The following is a description of a gene set: from publication Hill JA, Feuerer M, Tash K, Haxhinasto S, Perez J, Melamed R, Mathis D, Benoist C (PMID 18024188) studied in species Homo sapiens The transcription factor Foxp3 is usually considered the master regulator for the CD4+CD25+ Human Gene Set: GSE7460_CTRL_VS_FOXP3_OVEREXPR_TCONV_DN Genes down-regulated in comparison of Ctrlrv versus Foxp3rv (see Fig. 1 in the paper for details)., and this is the list of marker genes: NEPRO, LRP6, NTS, DDX27, MED9, CKAP4, SLC22A15, THAP1, MYBPH (NCBI Gene Id 4608), MPI (NCBI Gene Id 4351), WT1, PYROXD2, METTL26, SECTM1, DTD1, CYTH4, RABGGTB, TMEM273, MMP19, ZNF8 (zinc finger protein 8), RAB27A, BPNT2 (3'(2'), 5'-bisphosphate nucleotidase 2), TSPY1, SEC11C, USP22, ITGAE, PRMT6 (NCBI Gene Id 55170), GSTO1, BCL3, FLT1, PLD3, JAK1, TMEM184B, UFD1, TERF2, SLC4A7, INSIG2, AKAP7, SSBP2, GHDC, VIRMA, TMEM199 (NCBI Gene Id 170473), VWA2, SLC35A1, IPO13, PRR9, ANKMY2, ERP44, HIVEP2, TMED9, NAGLU, STX3, BCAP29, BRI3, CHM, CAVIN4, SLC12A6, NXPE4, VAV2, CYP8B1, INPP4B, GPR34, CFTR, TASP1, TEFM, RECK, SPATA21, PCDHB10, TAF12, CHD9, HELQ, NSD1, BTNL9, ARHGAP5, ADCYAP1, ACKR4, TNFAIP3, ACSM1, NF1, ACYP2, PURG (purine rich element binding protein G), MBTPS2, STARD5, MRI1, NRIP1, PHKG1, ALKBH6, JAKMIP3, DENND4A, HES6, DDB1, STRADB (STE20 related adaptor beta), SESN3, LINC01160, FAM83E, SLC16A14, WDFY4, SYPL1, SOCS2, AGPS, LRRC8D (NCBI Gene Id 55144), SCNN1G, FXYD7, EN1, GATA1, PPP1R2P1, SMAD1, TLR8, SOCS7, KHK, PTPMT1, SOD2, ENO3, ABHD4, KMT2D, HABP2, GRK4, SPTAN1, ADGRG3, TMEM174, DAGLB, COPE, IPMK, INTS9, NIF3L1, TP53TG5, SKIC3, ATPAF1, ZNF799, GNG7, GPT2, KLHL14, YIPF6, IKZF3, CATSPERD, EGFL8, SNAI3-AS1, SMIM17 (NCBI Gene Id 147670), TRIM8, CHST4, EEF2K, HIPK2, IRAK2, OAS2 (NCBI Gene Id 4939), ELOVL6, CA5A, LRRC28, CRELD1, USP27X, VPS26B, CCDC28A, CD244, NABP1, YPEL4, EXOC3L1 (NCBI Gene Id 283849), TMEM140, TGIF2, PEAK1, NEB (nebulin), GBF1, UBR2, RAB3A, TMEM168, FCSK, OLFM1, TMEM176A, PTGR2, BASP1, KCNK10, NCEH1, AVEN, CSRNP1, MAP3K8, DGCR6, NIBAN1, APOF, ZNF281, CLEC4D, CFAP157, METTL4, LSM7, ZNF467, SOX3, CCN3 (NCBI Gene Id 4856), TAF6, CHD1, F12, ANTXR2, KIAA0319L, TMEM123, EMC1, SNAPC5, PHLPP1, EDN2, CES5A, TMEM158, P3H2, DONSON, EHBP1, CPE